Given this list of marker genes MMP8, LTC4S, MCM2, HADH, FNBP4, SLC25A30, LGALS8, DCAF12, AQR, RAC1, PIK3C2A, DYNLRB1, TOLLIP, CD9, TNFRSF21, FTL, TECR, PXN (paxillin), ADTRP, DGKE, MUC1, PLA2G15, SYNJ2BP, CPT1A, IQGAP1, REV1, POMGNT1, IL1RAP, RPE, IPO7, WASHC4, CBFB, MGA, NSA2, DDX47, RBL2, CD300LF, TNFRSF13B, RTN4, SUPT6H, TFEC, P4HA2, SQLE, GRK5, SLC25A46, CPQ, EFHD2, EEA1, HMGN5, PLS3, ALG14, VAMP4, LUC7L3, COL4A2, SNX14, UBP1, MSN, TLR1, GPCPD1, UBR1, STARD5 (NCBI Gene Id 80765), MCMBP, GATA2, PTPN1, POLR1D, HELLS, NAF1, PITPNB, IL1RN, ROCK2 (NCBI Gene Id 9475), FTSJ3, CD5, CCNI, KCNH2, MYCBP2, CCDC137, HNRNPLL, DUT, ADAM10, LYPD8, ATAD2B, CHKA, MRPL42 (NCBI Gene Id 64974), SPTLC2, TMEM38B, URI1, DPH6, PARP12, ITGB1, LRPPRC, ATAD1, FKBP7, CSDE1, ERCC8, RRM1, B3GNT2, UBAP1, SIRPA, MSL1, OSBPL1A, TAF5L, DHX8, PARP4, KLF16, GSX1, PLG, VPS50, SLC30A5 (NCBI Gene Id 79021), BAIAP2 (NCBI Gene Id 10458), CEP350, PRKCH, UBA1 (ubiquitin like modifier activating enzyme 1), TTC7B, POLR3F, HNRNPM, GPC6, GBP7, EYA2, VOPP1, RNF20, H2BC5, GRIK5, TRIM39, ACOT9, PTBP1, CASP1, COTL1, ZRANB2, MACROD2, ANGPTL1, CARHSP1, NARF, PDHA1, TAF12, TMEM168 (transmembrane protein 168), GDF11, GTPBP1, LAMA4, RBM15B, CD1D, HHEX, XPR1, CMTM6, RARS1, CDCA7L, AP1AR, PMM2, FASN, GNA13, DDX3X, STAC2, OPA1, NSF, BMI1, DESI2, AFF4, MIDN, RNPEP, TRIM41, MRPL14, NINJ2, MOB1B, MGAT4B, MCM3, CRY2, RAB8B, EIF4B, CAPZA3, CNOT2, SOCS5, NAA30 (NCBI Gene Id 122830), SPN, CDC23, TIA1, USP2, TRAPPC13, CAPZA1, INO80 (NCBI Gene Id 84156), LRP6, BEX4, HIPK3, USP15, ACER1, IRAK4, DDA1, FIS1, LRRC58, B3GALT5, TRAFD1, SLC41A2, HNRNPDL, STAT2, CHUK, CTSC, QNG1, INTS11, SEL1L3, BST1, OGA, JAK1, here is a description of the gene set: Genes up-regulated in comparison of control dendritic cells (DC) at 0 h versus those stimulated with Gardiquimod (TLR7 agonist) at 0.5 h. mouse primary BMDCs were stimulated with tlr ligands and gene expression changes were profiled on Affymetrix arrays from publication Amit I, Garber M, Chevrier N, Leite AP, Donner Y, Eisenhaure T, Guttman M, Grenier JK, Li W, Zuk O, Schubert LA, Birditt B, Shay T, Goren A, Zhang X, Smith Z, Deering R, McDonald RC, Cabili M, Bernstein BE, Rinn JL, Meissner A, Root DE, Hacohen N, Regev A (PMID 19729616) studied in species Homo sapiens Human Gene Set: GSE17721_CTRL_VS_GARDIQUIMOD_0.5H_BMDC_UP